The following is a description of a gene set: Mouse Gene Set: GOBP_CELLULAR_RESPONSE_TO_GONADOTROPIN_RELEASING_HORMONE Any process that results in a change in state or activity of a cell (in terms of movement, secretion, enzyme production, gene expression, etc.) as a result of a gonadotropin-releasing hormone stimulus. Gonadotropin-releasing hormone (GnRH) is a peptide hormone responsible for the release of follicle-stimulating hormone (FSH) and luteinizing hormone (LH) from the anterior pituitary. GnRH is synthesized and released by the hypothalamus. studied in species Mus musculus, and this is the list of marker genes: Anxa5, Mgarp (NCBI Gene Id 99565), Gnrhr, Crhbp, Gpr173, Akr1c18, Umodl1